Given this list of marker genes RTP4, MX2, CAV1, IFIT1, GATM, CFI, MYCT1, TNFAIP6, TSLP (thymic stromal lymphopoietin), TFDP2, TGM5, C15orf48, DNAJC6, CFP, HPGD, HOXA3, STXBP6, IL31RA, KIT, ABLIM1, TDRD9, IFIT2, MFAP3L, SP110, CDC42EP3, SPINK2, PRKAR2B, HOXA5, SLC8A1, HOPX, ASB2, SLC6A13, GALNT12, TEX9, DBN1, CCR6, DHRS9, IL22RA2, IFIH1, GMPR, SLC5A3, SAMD9, ENSG00000304732, ADSS1, PTGS2, KRT18, ATP10A, XAF1, DHRS3, ZEB1, RAB27B, SLITRK4, SCN4B, ZNF93, FN1, OAS2, RETREG1, EPCAM, NR4A2, ALDH1A1 (NCBI Gene Id 96075), IFI44, MED18, HOXA9, MCM4, SOX4, RBPMS, ISG15, NAPSB, HS3ST3B1, OAS1, SLC27A6, NXPE3, TPSAB1, TM4SF1, SERPINE2, IDO1, OASL, AUTS2, HOXB-AS3, ANGPT1, AFF3, IRF7, SCN2A, LAMP5, HBD, TOX, CD1D, CXCL10, IRX3, C11orf96, FZD10-AS1, STS, EPSTI1, CMPK2, CHRNA6, ANGPT2, STAT1, DUSP4, BEND6, ZNF521, LILRA2, DDX60L (DExD/H-box 60 like), SAMD9L, ADCYAP1, LGALS3BP, USP18, TRIM9, IFIT3, CDKN1C, MEIS1, SMIM24, MCOLN2, HBBP1, FLNB, HOXB3, NEXN, SIGLEC17P, GBP1, ITGB7, ARG2, CLNK, REN, CDH1, HMGCS1, GPR18, DEFB1, TMT1B, OAS3 (NCBI Gene Id 4940), DMD, SPOCK1, RSAD2, IFI27, EGLN3, ZNF503, DDX60, THBS1, IFITM1, IL15, MX1, BTLA, PLAAT4, FLT3, GNAI1, LILRA5 (leukocyte immunoglobulin like receptor A5), GEM, LGALS2, INPP4B, TIMP3, TYRP1, PALLD, CLECL1P, NEGR1, FCER2, APOL6, BISPR, CEBPZOS, RIGI, DLC1, CADM1, LSP1, TMEM45A, EIF2AK2, FERMT2, LY6E, FBXL20, PLD4, BATF3, HERC5, IFI44L, MIR155HG, HBB, ARL4A, OLFM3, SLC9A3, TMEM255A, ZNF711, IGLL1, JCHAIN, ADGRA2, CKB, TMEM200A, UST, CALB1, ARHGAP5 (NCBI Gene Id 394), PCDH20 (NCBI Gene Id 80245), HBG1, CD38, IFI6, CFD, HOXA7, ADRB1, FGF18, CELA2B, OSBPL6, here is a description of the gene set: Genes up-regulated in CD34+ hematopoetic cells by expression of NUP98-HOXA9 fusion off a retroviral vector at 10 days after transduction. NUP98-HOXA9, the chimeric protein resulting from the t(7;11)(p15;p15) chromosomal translocation, is a prototype of several NUP98 fusions that occur in myelodysplastic syndromes and acute myeloid leukemia. We examined its effect on differentiation, proliferation, and gene expression in primary human CD34+ hematopoietic cells. Colony-forming cell (CFC) assays in semisolid medium combined with morphologic examination and flow cytometric immunophenotyping revealed that NUP98-HOXA9 increased the numbers of erythroid precursors and impaired both myeloid and erythroid differentiation. In continuous liquid culture, cells transduced with NUP98-HOXA9 exhibited a biphasic growth curve with initial growth inhibition followed by enhanced long-term proliferation, suggesting an increase in the numbers of primitive self-renewing cells. This was confirmed by a dramatic increase in the numbers of long-term culture-initiating cells, the most primitive hematopoietic cells detectable in vitro. To understand the molecular mechanisms underlying the effects of NUP98-HOXA9 on hematopoietic cell proliferation and differentiation, oligonucleotide microarray analysis was done at several time points over 16 days, starting at 6 hours posttransduction. The early growth suppression was preceded by up-regulation of IFNbeta1 and accompanied by marked up-regulation of IFN-induced genes, peaking at 3 days posttransduction. In contrast, oncogenes such as homeobox transcription factors, FLT3, KIT, and WT1 peaked at 8 days or beyond, coinciding with increased proliferation. In addition, several putative tumor suppressors and genes associated with hematopoietic differentiation were repressed at later time points. These findings provide a comprehensive picture of the changes in proliferation, differentiation, and global gene expression that underlie the leukemic transformation of human hematopoietic cells by NUP98-HOXA9. species: Homo sapiens from publication Takeda A, Goolsby C, Yaseen NR (PMID 16818636) Human Gene Set: TAKEDA_TARGETS_OF_NUP98_HOXA9_FUSION_10D_UP